The following is a description of a gene set: The aggregation, arrangement and bonding together of a set of components to form a non-canonical inflammasome complex. species: Mus musculus Mouse Gene Set: GOBP_NON_CANONICAL_INFLAMMASOME_COMPLEX_ASSEMBLY, and this is the list of marker genes: Casp4, Zdhhc9, Ogt, Gbp5, Gm12250, Zdhhc5, Gbp2, Nr4a1, Irgm2, Gbp2b (guanylate binding protein 2b)